Given this list of marker genes DUSP1, WDR76, CCNB1, BRD4, NDC80, BIRC5, BABAM2, MAD1L1, FEM1B, BRCA1, DYNC1LI1, SKA3, BRCC3, GEN1, TTI1, CUL4A, CCAR2, RNASEH2B, PROX1 (prospero homeobox 1), RPA2, SKA1, INCENP, KNL1, MAD2L1BP, ANAPC15, ETAA1 (ETAA1 activator of ATR kinase), ZWINT, TPR, MAP3K20 (mitogen-activated protein kinase kinase kinase 20), CRY1, RFWD3, CDK5RAP2, TELO2, AURKB, CHEK2, CDCA8, LCMT1, PPP1R10, BARD1, RAD51, FBXO4 (NCBI Gene Id 55087), TTI2 (NCBI Gene Id 80185), XRCC3, PRP4K, USP44, PRAP1, MAD2L1, BRCA2, here is a description of the gene set: Human Gene Set: GOBP_REGULATION_OF_CELL_CYCLE_CHECKPOINT Any process that modulates the frequency, rate or extent of cell cycle checkpoint. species: Homo sapiens